Given this list of marker genes Bloc1s6, Adal, Urad, Xdh, Nt5c1a, Pnp, Urah, Adk, Ada, Nt5e, Uox, Ptgdr, Nt5c1b, Nt5c2, Acp3, Nt5c3, here is a description of the gene set: species: Mus musculus Mouse Gene Set: GOBP_ADENOSINE_METABOLIC_PROCESS The chemical reactions and pathways involving adenosine, adenine riboside, a ribonucleoside found widely distributed in cells of every type as the free nucleoside and in combination in nucleic acids and various nucleoside coenzymes.